The following is a description of a gene set: The process whose specific outcome is the progression of the vestibulocochlear nerve over time, from its formation to the mature structure. This sensory nerve innervates the membranous labyrinth of the inner ear. The vestibular branch innervates the vestibular apparatus that senses head position changes relative to gravity. The auditory branch innervates the cochlear duct, which is connected to the three bony ossicles which transduce sound waves into fluid movement in the cochlea. Human Gene Set: GOBP_VESTIBULOCOCHLEAR_NERVE_DEVELOPMENT studied in species Homo sapiens, and this is the list of marker genes: ATP8B1, NRP2, NPR2, CHRNB2, TIFAB, DCANP1, PAX2, POU4F3, NRP1, SLITRK6, NEUROG1